Given this list of marker genes RHOG, RETREG3, EPB41L5, FAM98A, PAFAH1B1 (platelet activating factor acetylhydrolase 1b regulatory subunit 1), MTM1, GRPEL2, CDH2 (NCBI Gene Id 1000), SRP72, PEX19, UPK1A, HGF, EPHA10, IGFBP3, KLHL6, OTOP3, SGPP1, ACVR2B, SUPT6H, SNAP91, CAMK1D, ITGAL, ZNF275, LINC02693, CBX4, TARDBP, PCSK9, NTF4, PRKACB, CPEB3, KDM2B, AGAP1, GLCCI1, VGLL3, TTC21B, KCNT2, SLA, IRF2, C11orf87, ZNF132, RNF126 (NCBI Gene Id 55658), IQGAP3, DTD2, NR2C1, OCIAD1, ST18, NAA16, MEAK7, ADAM23, BFAR, COL19A1, PHTF2, RMI1, ZNF316, ADCY3, here is a description of the gene set: from publication Chen Y, Wang X (PMID 31504780) Human Gene Set: MIR3670 Genes predicted to be targets of miRBase v22 microRNA hsa-miR-3670 in miRDB v6.0 with MirTarget v4 prediction scores > 80 (high confidence targets). species: Homo sapiens